Given this list of marker genes GLMN, ENG, SMAD4, GDF2, ACVRL1, here is a description of the gene set: Human Gene Set: HP_GASTROINTESTINAL_ARTERIOVENOUS_MALFORMATION An anomalous configuration of blood vessels that shunts arterial blood directly into veins without passing through the capillaries and that is located in the gastrointestinal tract. Gastrointestinal arteriovenous malformation studied in species Homo sapiens